Given this list of marker genes RBM7, ADPRH, WNK3, CLDN11, GNAT2, MAP3K21, PRC1, PADI3, GTPBP1, CUX1, APLP2, MATN3, MTG2, C1QTNF4, NUDT16L1, CAB39L, TMEM68 (transmembrane protein 68), GNA14, CD3E, MRPL38, APIP (APAF1 interacting protein), RPL7L1, CRCP, DHX35, MAGED1 (NCBI Gene Id 9500), DYNC2H1, TIGD2, ZSWIM4, ANKRD49, NRP1, MRGPRX1, RUNDC1, MXD1, VPS45, BLOC1S2, GADL1, NDE1, JMJD4, TOR2A, PIM1, MRPL22, METTL4, TMEM30A, GTF2H3, NIPSNAP3B, SNAI3, GTF3C5, MFAP5, MTRF1, PHF3, CRADD, ADH5, ARL2BP, PSMC6, POLR3B, TTC39B, UQCRFS1, KLHDC9, SNAP23, DPY19L3, SRPX2, ZBTB8B, SLIT1, ECD, HSP90AB1, RPA1, PTGR3, ACTL7A, SLK, NHLRC4, SHLD2, PMM2, CPLX4, GGA1, HDDC2, MRPL1, CCT7, MIR132, EXOSC4, KRT15, MAN1C1, NHP2, TAF1B, PXMP2, FAM50A, RSAD2, IFIT2, UBE2O (ubiquitin conjugating enzyme E2 O), KLHL7, NAA20, PLEKHA5, HEMK1, GHDC, SLC16A7, TRIM55, SELENOP, H2AJ, CCL17, DPH6, SEZ6L, GINS1, KIF18A, ZNF18, POPDC3, ADRB2, LRRC40, EIPR1 (EARP complex and GARP complex interacting protein 1), XCR1, MYL10, UBQLN2, CHMP5, UCN2, MYO1D, RACGAP1, RNF38, E2F6, OMD, SALL2, ADSL (adenylosuccinate lyase), SDHAF3, TRANK1, CD82, RNF20, CTNNBL1, OAS3, NUCB2, ANGEL1, PCF11, MYL4, NAA25 (NCBI Gene Id 80018), CCT4, PRR13, PICK1 (NCBI Gene Id 9463), RHOA, ZBTB41, CD300LD, ABR (NCBI Gene Id 82701), STXBP5, SHMT2, CLCNKA, CHMP2A, HDGF, MNAT1, SDCCAG8, NOL12, FAM83B (NCBI Gene Id 222584), KCNG1, C1orf116, APOD, SYT11, RNF19A, ACTR3B, NFYA, TAGAP, STRA6, here is a description of the gene set: Genes up-regulated in bone marrow-derived macrophages at 180 min of stimulation with IL10 and LPS: wildtype versus IL10 knockout. Human Gene Set: GSE5589_WT_VS_IL10_KO_LPS_AND_IL10_STIM_MACROPHAGE_180MIN_UP from publication El Kasmi KC, Holst J, Coffre M, Mielke L, de Pauw A, Lhocine N, Smith AM, Rutschman R, Kaushal D, Shen Y, Suda T, Donnelly RP, Myers MG Jr, Alexander W, Vignali DA, Watowich SS, Ernst M, Hilton DJ, Murray PJ (PMID 17114459) studied in species Homo sapiens IL-10 or IL-6 stimulation of control 129xC57BL/6 murine bone marrow derived macrophages in the presence of LPS. We used microarrays to detail the global programme of gene expression changes in response to IL-6 or IL-10 stimulation in the presence of lipopolysaccharide. BMDMs were isolated from control, IL-6-/-, and IL-10-/- mice on a 129XBL/6 mixed background mice and differentiated in the presence of CSF-1 for 6-7 days. Cells were scraped and plated in 6 well plates at 2x10e6/well. Cells were washed with complete DMEM and rested for 1-2 hr before stimulation with combinations of IL-10 (10 ng/ml), IL-6 (2 ng/ml) or LPS (100 ng/ml) for 45 min or 180 mins. Complete biological replicates were performed.